Given this list of marker genes BCL6, XIAP, IL12A-AS1, SLC35C1, RAG2, TNFRSF13B, C8B, CD79A, MNX1, NDE1, P4HA2, HLA-DPA1 (major histocompatibility complex, class II, DP alpha 1), MEFV, CYBC1, FOXN1, VANGL1, IL10, PTPN22, BLNK, RAG1, PIK3R1, CTLA4, CD40LG, SPI1, ERAP1, PRF1, CD19, TFRC, CYBA, NCF4, SH2D1A (NCBI Gene Id 4068), NLRP3, IL12A, NCF2, C4A, BCL2, JAK3, IL7, PRTN3, CR2, LRRC8A (leucine rich repeat containing 8 VRAC subunit A), TCF3, TLR3, NLRC4, KLRC4, CCR1, CD79B, CFB, IFNGR1, MRTFA, BTK (NCBI Gene Id 695), CIITA, IRAK4, SLC39A7, UBAC2, C8A, HLA-DRB1, STAT4, FAS, IL23R, FCGR3B, DNASE1L3, CYBB, IGHM, WAS, TBK1, CARD9, IGLL1, WIPF1, CXCR4, HLA-B, FOXP3, NCF1 (NCBI Gene Id 653844), C4B, TNFRSF13C, ICOS, HLA-DPB1, ARPC1B, TLR4, here is a description of the gene set: Inflammation of the meninges. Meningitis species: Homo sapiens Human Gene Set: HP_MENINGITIS